The following is a description of a gene set: from publication Chen Y, Wang X (PMID 31504780) Genes predicted to be targets of miRBase v22 microRNA hsa-miR-4300 in miRDB v6.0 with MirTarget v4 prediction scores > 80 (high confidence targets). species: Homo sapiens Human Gene Set: MIR4300, and this is the list of marker genes: VPS36, PPP1R18, SPRYD4, DHRS2, HECTD3, SIRT2, MICAL3, ZNF510, SHPRH, FBXO10, MYCT1, MYORG, ATPAF1, RHOBTB1, SMCR8, CLEC4E, IPO13, RAB9B, RGR, MBNL3, KIAA0513, TNRC6B, AK9, ST8SIA1, MYO9B, HIC1, NUCB2, ZC2HC1C, NOA1, COL9A2, ABI2, HMGA1, GINS2, ATP11A, PPFIA4, NETO2, PTAR1, CDK19, ATP8A1, MAP3K2, LAMTOR3, CCDC157, FOXP4, EDA2R, PLXNA4, DUSP23, OR7D2, ATP8A2, NUMA1, STK36, THRB, NPTX1, RASGRP3, USP54, LMX1A (NCBI Gene Id 4009), RBPMS2, LY6G6C, KAT6A, PRX, FLRT1, PML, OR11A1